Given this list of marker genes WNT4, DHH, AR, WNT3, DCAF17, here is a description of the gene set: Aplasia/Hypoplasia of the fallopian tube species: Homo sapiens Human Gene Set: HP_APLASIA_HYPOPLASIA_OF_THE_FALLOPIAN_TUBE Aplasia or developmental hypoplasia of the fallopian tube.